The following is a description of a gene set: Mouse Gene Set: WP_OSTEOCLAST_SIGNALING Osteoclast signaling studied in species Mus musculus, and this is the list of marker genes: Itgb3, Spp1, Ifnb1, Slc9a1, Gpr68, Ctsk, Ifnar1, Atp6v1g1, Trpv5, Tnfrsf11a, Pdgfb, Tnfrsf11b, Tnfsf11, Acp5